Given this list of marker genes COPS7A, DCUN1D1, COPS7B, COPS8, GPS1, COPS5, RPL5, DCUN1D5, HIF1A (NCBI Gene Id 3091), RPL11, COPS3, CDKN2A, COPS9, EPAS1, DCUN1D4, DCUN1D3, COPS2, COPS4, DCUN1D2, COPS6, here is a description of the gene set: Any process that modulates the frequency, rate or extent of protein neddylation. Human Gene Set: GOBP_REGULATION_OF_PROTEIN_NEDDYLATION species: Homo sapiens